Given this list of marker genes EXOC8, KRAS, YBX3, RAC2, RAC3, EXOC2, RAC1, NRAS (NCBI Gene Id 4893), RALA, RALBP1, CDC42, HRAS, here is a description of the gene set: RalA downstream regulated genes Human Gene Set: WP_RALA_DOWNSTREAM_REGULATED_GENES studied in species Homo sapiens